The following is a description of a gene set: This event has been computationally inferred from an event that has been demonstrated in another species.<p>The inference is based on the homology mapping from PANTHER. Briefly, reactions for which all involved PhysicalEntities (in input, output and catalyst) have a mapped orthologue/paralogue (for complexes at least 75% of components must have a mapping) are inferred to the other species. Reactome Pathway: Gap junction trafficking studied in species Mus musculus part of: Gap junction trafficking and regulation electronically inferred by orthology from the curated human pathway, and this is the list of marker genes: Gja3, Gjd2, Tubb4a, Tubb2b, Gjb4, Tubb4b, Tuba1c, Tubb6, Gjb2, Ap2m1, Tuba8, Gjd3, Tuba4a, Tubal3, Dnm2, Gjb5, Tuba3b, Tuba1b, Gja1, Tuba1a (NCBI Gene Id 22142), Cltb, Gja4